The following is a description of a gene set: Reactome Pathway: Signaling by PDGFRA extracellular domain mutants species: Homo sapiens Mutations in the extracellular domain of receptor tyrosine kinases like PDGRFA have the potential to interfere with glycosylation, which is required for proper trafficking to the cell surface. Versions of PDGFRA bearing mutations in the extracellular domain have been identified in some cancers, and while some of these are inactive, some have also been shown to signal constitutively from the endoplasmic reticulum. PDGFRA Y288C carries a mutation in the extracellular domain of the receptor that prevents the normal trafficking of the protein to the plasma membrane. PDGFRA Y288C is trapped in the endoplasmic reticulum membrane, from where it is able to signal constitutively in the absence of ligand. Similarly, a version of PDGFRA bearing an in-frame deletion of exons 8 and 9 has been identified in glioblastoma. The resulting protein is constitutively active in the absence of ligand despite the low fraction of protein expressed at the cell surface. part of: Signaling by PDGFR in disease, and this is the list of marker genes: PIK3R1, STAT1, STAT3, GRB2, HRAS, PIK3CB, NRAS, PIK3CA, KRAS, PDGFRA, PIK3R2, SOS1